Given this list of marker genes Gli3, Evc, Rara, Twsg1, Smad1, Smad5, Osr1, Rela, Mmp13, Arid5a, Nfia, Timp1, Mustn1, Zbtb16, Idua, Matn3, Ror2, Carm1, Hoxd11, Bmp5, Sfrp2, Ext2, Ccn3, Ccn1, Mef2d, Serpinh1, Chsy1, Dicer1, Rarb, Hmga2, Barx2, Zeb1, Fgf2, Nkx3-2, Prkca, Fgfr3, Frzb, Hyal1, Bmpr2, Hand1, Hspg2, Ccn2, Kat2a, Trpv4, Bmp7, Uncx, Fgf6, Bmpr1b, Smad9, Atp7a, Pth, Cst5, Bmp1, Ogn, Col1a1, Hoxb3, Ift80, Hoxc4 (homeobox C4), Thrb, Smad7, Nppc, Mef2c, Zmpste24, Hif1a, Optc, Rflnb, Pth1r (parathyroid hormone 1 receptor), Tapt1, Pthlh (NCBI Gene Id 19227), Trip11, Bmp3, Prrx1, Wnt2b, Cer1, Matn1, Ltbp3 (latent transforming growth factor beta binding protein 3), Pbxip1, Stc1, Sox6, Creb3l2, Bbs1 (NCBI Gene Id 52028), Satb2, Fgf4, Sulf2, Snx19, Tgfb2, Epyc, Cbs (NCBI Gene Id 224676), Wnt7a, Sulf1, Axin2, Bpnt2, Msx1, Pkd1, Myf5, Lnpk, Sox5 (NCBI Gene Id 319649), Gata3, Snai1, Mboat2, Wnt7b, Nog, Wnt5a, Col3a1, Thbs1, Mia3, Pitx1, Thbs3, Grem1, Glg1, Ctnnb1, Ddrgk1, Maf (MAF bZIP transcription factor), Zbtb7a (NCBI Gene Id 71606), Srf, Atf2, Snorc, Ihh, Bgn, Itgb8, Gli2, Dlx2, Mycn, Ptpn11, Adamts12, Mgp, Edn1, Bbs2, Hand2, Bmp8a, Mkx, Lrp6, Gdf2, Fgf9, Mapk14, Errfi1, Fgfr1, Bmp8b (NCBI Gene Id 12164), Tgfbr2, Fbxw4, Prrx2, Hoxa5 (NCBI Gene Id 15402), Snai2, Col2a1, Otor, Gnas, Gpld1, Tgfb1, Dspp, Ecm1, Prkg2, Npr2 (natriuretic peptide receptor 2), Cr2, Bmp10, Eif2ak3, Nfib, Lep, Osr2, Csgalnact1, Wnt10b, Hyal3, Mir140, Ep300, Runx1, Col10a1, Fgf18, Col11a1, Nfatc2, Hoxd3, Scin, Pax7, Adamts7, Por, Sik3 (NCBI Gene Id 77161), Loxl2, Ccn4, Msx2, Mdk, Col9a1, Sox9, Hes5, Thra, Tgfbi, Col11a2, Trps1, Tyms, Mkks, Chadl, Cnmd, Fosl2, Bmpr1a, Smpd3, Enpp1, Runx2, Hyal2, Cfh (complement component factor h), Bmp4, Wnt9a, Runx3, Tgfbr1, Rb1, Scx, Nr5a2, Ext1, Pkdcc, Shox2, Cytl1, Hoxa11, Gdf6, Efemp1, Il17f (NCBI Gene Id 96930), Acan, Esrra, Gdf5, Smad3, Chrdl2, Mex3c, Col27a1, Scube2, Hoxa3, Six2, Slc39a14, Zfp219, Galnt3, Rflna (refilin A), Slc26a2, Rspo2 (NCBI Gene Id 75417), Bmp2, Rarg, Col6a1, Mapk3, Comp, Poc1a, Ctsk, Bmp6, Chst11, here is a description of the gene set: studied in species Mus musculus Mouse Gene Set: GOBP_CARTILAGE_DEVELOPMENT The process whose specific outcome is the progression of a cartilage element over time, from its formation to the mature structure. Cartilage elements are skeletal elements that consist of connective tissue dominated by extracellular matrix containing collagen type II and large amounts of proteoglycan, particularly chondroitin sulfate.